Given this list of marker genes Iqschfp, Foxd1, Pclo, Prrg1, Cxcl16, Schip1, here is a description of the gene set: species: Mus musculus from publication Chen Y, Wang X (PMID 31504780) Mouse Gene Set: MIR_471_5P Genes predicted to be targets of miRBase v22 microRNA mmu_miR_471_5p in miRDB v6.0 with MirTarget v4 prediction scores > 80 (high confidence targets).